The following is a description of a gene set: Pathway Definition from KEGG: ORC == CDC6 == CDT1 == MCM -> pre-RC+DDK == CDC45+TICRR+MTBP == CDK studied in species Homo sapiens DNA replication licensing. Pathway ID: N01468. Pathway type: Reference. Pathway class: nt06509 DNA replication. Human Gene Set: KEGG_MEDICUS_REFERENCE_DNA_REPLICATION_LICENSING, and this is the list of marker genes: ORC2, CDC6, CDT1, CCNA2 (NCBI Gene Id 890), ORC6, CCNE1, ORC4, ORC5, DBF4, MCM3, MCM6, MCM7, CCNA1, ORC1, TICRR, CDK2, CDC7, MCM4, CCNE2, MTBP, ORC3 (NCBI Gene Id 23595), CDC45, MCM2, MCM5